Given this list of marker genes Egln3, Egln1, P4ha3, P4ha1, P3h3 (NCBI Gene Id 14789), P4hb, Egln2, P4ha2, P3h2, P3h1 (NCBI Gene Id 72188), Ogfod1, P4htm, here is a description of the gene set: Catalysis of the reaction: peptidyl L-proline + 2-oxoglutarate + O2 = peptidyl hydroxy-L-proline + succinate + CO2. studied in species Mus musculus Mouse Gene Set: GOMF_PEPTIDYL_PROLINE_DIOXYGENASE_ACTIVITY